The following is a description of a gene set: Mouse Gene Set: GOBP_POSITIVE_REGULATION_OF_AMYLOID_BETA_FORMATION species: Mus musculus Any process that activates or increases the frequency, rate or extent of amyloid-beta formation., and this is the list of marker genes: Ifngr1 (interferon gamma receptor 1), Rock2 (NCBI Gene Id 77848, Rho-associated coiled-coil containing protein kinase 2), Gsap, Rela, Ifng, Gsk3a, Clu (clusterin), Chrna7, Epha4, Sp1, Efna1, Picalm, Slc2a13, Abca2, Tnf, Abcg1, Casp3, Csnk1e, Lrrtm3, Apoe